Given this list of marker genes NGF, RIPK1, TRAP1, FASLG, TRIM37, CFLAR, MYD88, BEX3, SIVA1, DAB2IP, PIDD1, TNFSF4, TRAF5, TNFSF13, TRAF4, TNFSF14, TNFSF9, CD40LG, TRAF2, CASP3, CD70, TRAF6, CASP8AP2, FEM1B, TNFSF18, MADD, TNFSF15, TRAF3, ADAM8, CASP8, NTF3 (neurotrophin 3), LTB, TRAF1, BID, TNFSF12, FADD, NTF4, TMBIM1, TNFSF13B, TNFSF10, TNF, STAT1, TNFSF11, BDNF, TNFSF8, BABAM2, LTA, NOL3, EDA, here is a description of the gene set: studied in species Homo sapiens Binding to a member of the tumor necrosis factor receptor superfamily. Human Gene Set: GOMF_TUMOR_NECROSIS_FACTOR_RECEPTOR_SUPERFAMILY_BINDING